Given this list of marker genes Adora1, Drd3, Pla2g6, Npy2r, Myo5a, Htr1b, Htr2a, Prkn, Grik2, Grik3, Atad1, Grik1, Drd2, here is a description of the gene set: Any process that stops, prevents, or reduces the frequency, rate or extent of glutamatergic synaptic transmission, the process of communication from a neuron to another neuron across a synapse using the neurotransmitter glutamate. Mouse Gene Set: GOBP_NEGATIVE_REGULATION_OF_SYNAPTIC_TRANSMISSION_GLUTAMATERGIC species: Mus musculus